Given this list of marker genes Cyb5b, Cyb5r3, Mb, Cygb, Ngb, Mtarc2 (mitochondrial amidoxime reducing component 2), Cyp1a2, Cbs, Xdh, Mtarc1, here is a description of the gene set: Mouse Gene Set: GOMF_NITRITE_REDUCTASE_ACTIVITY Catalysis of the reaction: nitrite + acceptor = product(s) of nitrate reduction + reduced acceptor. studied in species Mus musculus